Given this list of marker genes LRPAP1, LRP1, CLTC, RAB11B (RAB11B, member RAS oncogene family), RAB11A, RAB5A, PICALM, here is a description of the gene set: The process in which amyloid-beta is removed from extracellular brain regions by cell surface receptor-mediated endocytosis, followed by transcytosis across the blood-brain barrier. Human Gene Set: GOBP_AMYLOID_BETA_CLEARANCE_BY_TRANSCYTOSIS studied in species Homo sapiens